Given this list of marker genes SLC26A5, GPSM2, NUMA1, KCNE3, KCNQ1, here is a description of the gene set: The region of a polarized cell other than its tips or ends (in some cell types, one end may be called the apex and the other the base). For example, in a polarized epithelial cell, the lateral part includes the cell sides which interface adjacent cells. Human Gene Set: GOCC_LATERAL_PART_OF_CELL studied in species Homo sapiens